The following is a description of a gene set: Human Gene Set: GOBP_INTRACELLULAR_LIPID_TRANSPORT studied in species Homo sapiens The directed movement of lipids within cells., and this is the list of marker genes: TMEM41B, STAR, RELCH, TSPO2, SLC25A20, CPT2, OSBP, ABCD3, VPS4A, GRAMD1B, ABCD2, NPC2 (NPC intracellular cholesterol transporter 2), SERAC1, NUS1, VPS52, MIR17, CPT1B, CES1, ANXA2P2, ARL8B, CERT1, ARV1, GRAMD1A (NCBI Gene Id 57655), MIR185, VPS51, ABCA2, SCP2, ABCA1 (ATP binding cassette subfamily A member 1), ABCD1, VPS54, ANXA2, SGPP1, TMEM97, VPS53, ABCG1, TPCN2, LDLRAP1, OSBPL2, PCSK9, PIP4K2A, FABP3, NPC1, STARD4, PLEKHA8, ABCD4, CPT1A, GRAMD1C, ABCA12, LDLR, MIR27B, SYT7 (synaptotagmin 7)